The following is a description of a gene set: The process in which the anatomical structures of the trabecular cardiac ventricle muscle are generated and organized. Human Gene Set: GOBP_VENTRICULAR_TRABECULA_MYOCARDIUM_MORPHOGENESIS studied in species Homo sapiens, and this is the list of marker genes: MED1, FOXH1, TGFB2, UBE4B, NRG1, RBPJ, CHD7, BMPR1A, NKX2-5, DLL4, NOTCH1, HEY2, HEG1 (NCBI Gene Id 57493), ENG, TGFBR1